Given this list of marker genes Pthlh, Slc20a1, Ankrd1, Jag1, Rgs16, Plk3, Tfpi2, Spata13, Cdyl2, Rasl11b, Ppp1r13l, Fstl3, Aldh1a3, Pmepa1, Klf13, F2rl1, Slc41a2, Lpin3, Cx3cl1, Tmcc3, Snai1, Fgf18 (fibroblast growth factor 18), Cspg4, Rap1gap2, Mfsd2a, Hck, Hk2, Cd40, Ppp1r15a, Lif (leukemia inhibitory factor), Itga5, Il11, Junb, Ccl17, Tnfrsf12a, Mgll, Enpp1, Unc5b, Sphk1, Hbegf, Otud7a, Plekhg3, Baiap2l1, Klhdc8a, Ptk2b, Prag1, Lrrc8c, Bmal1, Tnfrsf11b, Mmp9, Acta1, Als2cl, Col8a2, Rbfox1, Nfatc1, Gfpt2, Fgf2, Nes, Pdgfb, Fgf21, Nfil3, Nuak2, Hspa2, Mcam, Tnnt2 (troponin T2, cardiac), Il18r1, Lrrfip1, Dusp14, Pdgfc, Tnfaip3, Cnn1, Sema7a, Ube2g2 (NCBI Gene Id 68471), Ier3, Has2, Meox1, Card10, Stk38l, Grem2, Maff, Nuak1, Timp3, Entpd7, Vegfa, Galnt3, Prkar2a, Creb3l2, Gucy1b1, Heyl, Adam12, Ip6k1, Cxcl14, Abcb1a, Ccn2, Khdrbs3, Kctd11, Pmaip1, Itgb3, Dusp6, Zfp469, Gcnt2, Ank, Ereg, Megf10, Fosl1, Hip1r, Hey1, Garem2, Las1l, Tspan2, Ass1, Pkp1, Gfod1, Runx1, Pde4dip (phosphodiesterase 4D interacting protein (myomegalin)), Pdgfa, Olr1 (oxidized low density lipoprotein (lectin-like) receptor 1), Fkbp5, Dusp5, Klhl29, Aldh1a2, Hmga2-ps1, Rnf19b, Endod1, Bhlhe40, Gja3, Ivns1abp, Fxyd6, Slc2a1, Olfm2, Serpine1, Tgfb1, Siah2, Arc, Gper1, Eln, Flnb, Il6, Gjb3, Cmklr1, Wnt11, Sfn, Htr2b (5-hydroxytryptamine (serotonin) receptor 2B), Lrp8, Pvr, Wnt9a, Tnc (NCBI Gene Id 21923), Myo1d, Ccl20 (C-C motif chemokine ligand 20), Rnf149, Egr2, Stmn4, Cxcr6, Nipal1, Prg4, Nebl, Csrnp1, Chst11, Ngf, Inhba, Foxs1, Pi4k2b, Abtb3, Prkg2, Tgfbr1, Lmo1 (NCBI Gene Id 16908), Hivep3, Ntf5, Cdh6, Papss2, Ptgs2, Plaur, Crispld2, Kcnk1, Gatm, Car6, Serp1, Arg1, Fjx1, Hectd2, Cry1, Nppb, Mical2, Thbs4 (NCBI Gene Id 21828), Fbxo32 (NCBI Gene Id 67731), Nrarp (NCBI Gene Id 67122), Gjb2, Foxc2, Gch1, Flt1, Ttc9, Ier2, Socs2, Gadd45b, Elavl2, Gpr84, Cth, here is a description of the gene set: Mouse Gene Set: PLASARI_TGFB1_TARGETS_10HR_UP Genes up-regulated in MEF cells (embryonic fibroblast) upon stimulation with TGFB1 for 10 h. species: Mus musculus Transforming growth factor beta (TGF-beta) and platelet-derived growth factor A (PDGFAlpha) play a central role in tissue morphogenesis and repair, but their interplay remain poorly understood. The nuclear factor I C (NFI-C) transcription factor has been implicated in TGF-beta signaling, extracellular matrix deposition, and skin appendage pathologies, but a potential role in skin morphogenesis or healing had not been assessed. To evaluate this possibility, we performed a global gene expression analysis in NFI-C(-/-) and wild-type embryonic primary murine fibroblasts. This indicated that NFI-C acts mostly to repress gene expression in response to TGF-beta1. Misregulated genes were prominently overrepresented by regulators of connective tissue inflammation and repair. In vivo skin healing revealed a faster inflammatory stage and wound closure in NFI-C(-/-) mice. Expression of PDGFA and PDGF-receptor alpha were increased in wounds of NFI-C(-/-) mice, explaining the early recruitment of macrophages and fibroblasts. Differentiation of fibroblasts to contractile myofibroblasts was also elevated, providing a rationale for faster wound closure. Taken together with the role of TGF-beta in myofibroblast differentiation, our results imply a central role of NFI-C in the interplay of the two signaling pathways and in regulation of the progression of tissue regeneration. from publication Plasari G, Calabrese A, Dusserre Y, Gronostajski RM, McNair A, Michalik L, Mermod N (PMID 19752192)